Given this list of marker genes Ifnz, Irf8, Mir181b-2 (NCBI Gene Id 723903), Itm2a, Ifnb1, Gm13275, Notch2, Plcl2 (NCBI Gene Id 29868), Enpp1, Il10, Ifna11, Ifna2, Atad5, Hmces, Pms2, Itfg2, Spi1, Supt6, Gm13272, Bcl3, Cd40lg, Exosc6, Ifna13, Lgals1, Ptprc, Stat6, Ada, Xrcc4, Lfng, Gm13276, Hspd1, Gm13277, Rnf168 (NCBI Gene Id 70238), Ptk2b, Icosl (NCBI Gene Id 50723), Cd28, Sanbr, Il27ra, Il21, Ifna1, Parp3, Ifna16, Mlh1, Exo1 (NCBI Gene Id 70554), Mir181b-1, Batf, Pcyt1a, Cd180, Ifnk, Paxip1, Rnf8, Nbn, Foxp3, Gm13283, Dock11, Tfrc (NCBI Gene Id 76361), Ifna15, Aicda, Plcg2, Abl1, Ung, Lig4, Tlr4, Shld1, Il4, Ifna12, Nsd2, Kmt5c, Ddrgk1, Il2, Tnfsf13, Gpr183, Dll1 (NCBI Gene Id 13388), Tgfb1, Ifna6 (interferon alpha 6), Lgals8, Dock10, Ercc1, Gapt, Shld3, Ndfip1, St3gal1, Tnfaip3, Rif1, Ifnab, 6030468B19Rik, Phf14, Ifna4, Ifna9, Aplf, Mfng, Nkx2-3, Shld2, Tnfsf4 (NCBI Gene Id 226545), Il6, Trp53bp1, Muc19, Clcf1, Tbx21, Gm13271, Cd19, Rag2, Exosc3, Ifna7, Pagr1a, Ccr6 (C-C motif chemokine receptor 6), Mad2l2, Ifna14, BC037156, Ifna5, Swap70, Lilrb4a, Msh2, Kmt5b, Nfkbiz, Pou2af1, Xbp1, Msh6, Ifne, Cdh17, Slc15a4, Cd40, Bcl6, Ifng, here is a description of the gene set: The change in morphology and behavior of a mature or immature B cell during an immune response, resulting from exposure to a mitogen, cytokine, chemokine, cellular ligand, or an antigen for which it is specific. Mouse Gene Set: GOBP_B_CELL_ACTIVATION_INVOLVED_IN_IMMUNE_RESPONSE species: Mus musculus